Given this list of marker genes TYROBP, TNFRSF13B (TNF receptor superfamily member 13B), FCGR2B, INPP5D, RC3H1, MIR185, CTLA4, CDKN2A, TNFRSF21, MNDA, ATM, CD300A, PAWR, PKN1, CASP3, LYN, IL10, BTK, here is a description of the gene set: Human Gene Set: GOBP_NEGATIVE_REGULATION_OF_B_CELL_PROLIFERATION Any process that stops, prevents or reduces the rate or extent of B cell proliferation. studied in species Homo sapiens